Given this list of marker genes SCGB3A1, S100A9, C4BPA, SFTPB, RNASE1, PIGR, PTPN13, CACNA2D2, C3, SFTA3, SCGB3A2, LAMP3, LRRK2, DUOX1, AK1, LPCAT1, SFTA2 (NCBI Gene Id 389376), DMBT1, PGC, SFTPA1, EPHX1, NNMT, DHCR24, SFTPA2, HSD17B6, NAPSA, SERPINA1, SDR16C5, MID1IP1, TFPI, SLPI, SFTA1P, SCD, FABP5, ABCA3, SLC22A31, ALPL, ALOX15B, SFTPC, AQP1, NPC2, SUSD2, CXCL17, MFSD2A, HOPX, SFTPD, C16orf89, SPINK5, PEBP4, FASN, here is a description of the gene set: Genes upregulated in subsets of cells of a given type within various tumors from publication Gavish A, Tyler M, Greenwald AC, Hoefflin R, Simkin D, Tschernichovsky R, Galili Darnell N, Somech E, Barbolin C, Antman T, Kovarsky D, Barrett T, Gonzalez Castro LN, Halder D, Chanoch-Myers R, Laffy J, Mints M, Wider A, Tal R, Spitzer A, Hara T, Raitses-Gurevich M, Stossel C, Golan T, Tirosh A, Suvà ML, Puram SV, Tirosh I (PMID 37258682) species: Homo sapiens Human Gene Set: GAVISH_3CA_MALIGNANT_METAPROGRAM_31_ALVEOLAR In this study, an extensive analysis was conducted to define meta-programs (MPs) capturing intra-tumor heterogeneity across a spectrum of tumor types. The approach utilized non-negative matrix factorization (NMF) to analyze each cell type separately within individual tumor samples. This involved the analysis of malignant cells, macrophages, fibroblasts, endothelial cells, epithelial cells, T-cells, and B-cells. NMF was executed with varying parameter values (K=4, 5, 6, 7, 8, 9), thereby generating 39 programs for each cell type per sample. Each NMF program was summarized by the top genes based on NMF coefficients.\nRobust MPs were then delineated for each cell type using a set of stringent criteria, including recurrence within the same tumor, similarity to programs in other tumors, and non-redundancy within a tumor. Subsequently, these robust NMF programs were clustered (per cell type) based on Jaccard similarity, leading to the identification of MPs associated with each cell type.\nTo enhance the quality of the MPs, a refinement steps were undertaken, involving the removal of MPs suspected of reflecting low-quality data (with an overrepresentation of ribosomal proteins or mitochondrial-encoded genes), single-study inclusion, or similarity to miss-annotated cell types.